Given this list of marker genes OVGP1 (oviductal glycoprotein 1), CHI3L2, CTBS, CHIA, CHIT1, CHI3L1, here is a description of the gene set: Human Gene Set: GOBP_CHITIN_METABOLIC_PROCESS The chemical reactions and pathways involving chitin, a linear polysaccharide consisting of beta-(1->4)-linked N-acetyl-D-glucosamine residues. studied in species Homo sapiens